Given this list of marker genes Lims2, Ilk, Parva, Flnc (NCBI Gene Id 68794), Actb, Lims1, Fermt2, Fblim1, Pxn, Actg1, Rsu1, Itgb1, Flna, Actn1, Arhgef6, Tesk1, Vasp, Parvb, here is a description of the gene set: Cell-extracellular matrix interactions species: Mus musculus Mouse Gene Set: REACTOME_CELL_EXTRACELLULAR_MATRIX_INTERACTIONS